Given this list of marker genes Pkhd1, Sec24b, Erbb4, Sfrp1, Exoc5, Dchs1, Fat4, Intu, Cthrc1, Celsr1, Pafah1b1, Dlg3 (discs large MAGUK scaffold protein 3), Hnf4a, Brsk2, Sapcd2, Jhy, Vangl2, Ptk7, Rpgrip1l, Wnt5a, Fuz, Sfrp2, Trp63, Wnt9b, Cplane1, Spag6l (sperm associated antigen 6-like), Grhl3, Foxf2, Wdpcp, Ift20, Fzd6, Sfrp5, Wdr1, Astn2, Fzd3, Alms1, Brsk1, Ttc8, Nphp1, here is a description of the gene set: studied in species Mus musculus Mouse Gene Set: GOBP_ESTABLISHMENT_OF_TISSUE_POLARITY Coordinated organization of groups of cells in a tissue, such that they all orient to similar coordinates.